The following is a description of a gene set: Human Gene Set: HP_SAGITTAL_CRANIOSYNOSTOSIS Sagittal craniosynostosis studied in species Homo sapiens A kind of craniosynostosis affecting the sagittal suture., and this is the list of marker genes: AHDC1, EIF4A2, RAB23, IL11RA, TWIST1, RECQL4, CDC45, TCF12, IFT122, DPH1, TBC1D24, ERF, WDR19, HNRNPK (NCBI Gene Id 3190), SPECC1L, FBXO11, FGFR2, DNMT3A, IFT43, DPH2, RNU12, ATP6V1B2, GLIS3, DPF2, KRAS, SON